The following is a description of a gene set: Human Gene Set: MIR519E_3P Genes predicted to be targets of miRBase v22 microRNA hsa-miR-519e-3p in miRDB v6.0 with MirTarget v4 prediction scores > 80 (high confidence targets). species: Homo sapiens from publication Chen Y, Wang X (PMID 31504780), and this is the list of marker genes: CSRNP3, FAT2 (NCBI Gene Id 2196), ZSWIM6, FEZF1, PTPN4, SYT1 (NCBI Gene Id 6857), PRAMEF17 (NCBI Gene Id 649345), ZNRF3, TBC1D2, MTRF1L, DLG2, DAZAP2, PAFAH1B1, PFN2, BCL11B, C5AR2 (complement C5a receptor 2), DPYSL5, PTPRG, PRICKLE3, AADAC, TBC1D17, TENM3, MCF2L, TRAK1, LRP8, ZNF513, WAC, PLBD1, TBC1D3, DLL1, YPEL4, DOCK4, BNIP5, BAZ1B, TBC1D3H, KIAA1549L, ITPRID2, GABBR2, GGCX, RNF11, NR1D2, TOB1, KCNJ13, PAPOLB, NR4A2, ST6GAL2, BICD2, DCUN1D3, CLOCK, CYB561D1, TLN2, PPP1R7, CBLL1, CACNA1D, ZNF280B, PAFAH1B2, EPHA7 (EPH receptor A7), SETD3, URI1, NPAS2, IGSF10 (immunoglobulin superfamily member 10), ATG14, MAPK6, GDAP1, ZNF213, AGO1